The following is a description of a gene set: studied in species Mus musculus Mouse Gene Set: GOBP_TOLL_LIKE_RECEPTOR_2_SIGNALING_PATHWAY The series of molecular signals initiated by a ligand binding to toll-like receptor 2., and this is the list of marker genes: Pja2, Cyba, F2rl1, Hmgb1, Pik3ap1, Mfhas1, Irak1, Acod1, Ripk2, Tlr1, Nod2, Lyn, Tnip2, Tlr6, Tirap, Trem2, Tlr2